Given this list of marker genes NRG3, DRD2, CNTN2, ARL13B, FEZF2, DRD1, LHX6, ARX, here is a description of the gene set: The directed movement of interneurons from the subpallium to the cortex during forebrain development. Human Gene Set: GOBP_INTERNEURON_MIGRATION_FROM_THE_SUBPALLIUM_TO_THE_CORTEX species: Homo sapiens